Given this list of marker genes FRZB, VEGFB, FGF2, WNT5B, NOTCH2, NOTCH3, ID1, PLXDC1, FZD5, VEGFA, FGFR3 (NCBI Gene Id 55546), C10orf55, NOTCH1, CXCL1, PRSS23, CXCR2, NAA15, ID3, PDGFRB, DIXDC1, NPR1, CNMD, FLT4, TYMP, CCL2, TGFA, IGF1, DLL1, DDI1 (NCBI Gene Id 414301), THBS1-IT1, TIMP3, WNT7B (NCBI Gene Id 7477), EPAS1, PDGFRA, CHGA, TNFRSF12A, ADGRB1, CXCL5, WNT2B, GRB14, CHRM4, HEYL, ANGPT1, RAMP1, EPHA4, OSM, EGF, DVL1, CCN2, MMP2 (NCBI Gene Id 4313), BTG1, CSF3, NRP2, LPXN, EPHB3, CFH, CXCL8, RPS20P22, RHOB, EPHA2 (EPH receptor A2), PTN, HSPB2, EPHA7, PHEX, CD36, FZD8, RAMP2, FGFR1, CDH5, DVL3, EPHA8, FGFR4, EPHA3, ANGPTL4, SFRP1, LAMA5, TMPRSS6, ANGPTL1, THBS1, FZD10, ERBB2, TGFB1, ANG, EREG, KLLN, CFHR3, TNFSF15, FZD1, LEP, EPHB6, EPHA10, PLG, TIE1, KLK3, EFNA5, CEACAM1, F7 (NCBI Gene Id 14068), SFRP5, MDK, PROK2, FZD7, FZD3, STAB1, FGF6, DLL3, IL17F, ANPEP, FRS3, TGFB2, F2, FRS2, PDGFC, MMP19, FGFR2 (NCBI Gene Id 2263), PTEN, HEY2, SDAD1-AS1, FZD2, IFNG, EPHA5 (EPH receptor A5), DVL2, ANGPTL3, NPPB, SERPINB5, TMEM198B, NUDT6, WNT7A, SLC19A1, EPHB2, HGF, F2RL1, HAND2, PTGS1, EPHB4, here is a description of the gene set: studied in species Homo sapiens Angiogenic markers down-regulated in lymph endothelial cells upon infection with KSHV (Kaposi's sarcoma herpes virus). Human Gene Set: VART_KSHV_INFECTION_ANGIOGENIC_MARKERS_DN Kaposi's sarcoma (KS) is caused by Kaposi's sarcoma-associated herpesvirus (KSHV) and consists of proliferating spindle cells, which are related to lymphatic endothelial cells (LEC). Angiopoietin-2 (Ang2) is a secreted proangiogenic and lymphangiogenic molecule. Here, we show the expression of Ang2 protein in KS and confirm that KSHV infection up-regulates Ang2 in LEC. We show that a paracrine mechanism contributes to this up-regulation. A lentiviral library of individual KSHV-encoding genes, comprising the majority of known latent genes and a selection of lytic viral genes, was constructed to investigate the underlying mechanism of this up-regulation. Two lytic genes, viral interleukin-6 (vIL6) and viral G-protein-coupled receptor (vGPCR), up-regulated Ang2 expression in LEC. Both vIL6 and vGPCR are expressed in KSHV-infected LEC and caused up-regulation of Ang2 in a paracrine manner. KSHV, vIL6, and vGPCR up-regulated Ang2 through the mitogen-activated protein kinase (MAPK) pathway. Gene expression microarray analysis identified several other angiogenic molecules affected by KSHV, including the vascular endothelial growth factor (VEGF)/VEGF receptor (VEGFR) axis, which is also affected by vIL6 and vGPCR in LEC, and matrix metalloproteinases, which could act in concert with Ang2 to contribute to KS development. These findings support the paracrine and autocrine roles of the lytic KSHV-encoded proteins, vIL6 and vGPCR, in KS pathogenesis and identify Ang2 as a potential therapeutic target for this neoplasm. from publication Vart RJ, Nikitenko LL, Lagos D, Trotter MW, Cannon M, Bourboulia D, Gratrix F, Takeuchi Y, Boshoff C (PMID 17483315)